Given this list of marker genes MYL4, GMFG, SPHK2, CRAT, FBXO3, BRCA1, APIP, ZDHHC4, FOXI1, CDH10, CYFIP1, GUCA1A, GEMIN7, COPZ1, TBC1D31, ERCC6L, MSRB2, PKD2, OAZ2, PTGR2, VASP, SLK, POC1A, SSU72, ATAD5, NDC80, SCP2, EGFL7, CHEK2, SDHD (succinate dehydrogenase complex subunit D), STRADB, VPS26A, SCMH1, C4orf46, TNFRSF1A, TLR1, TMEM79, N4BP1, RNASE1, NIPA1, VPS13B, TLX2 (NCBI Gene Id 51407), KIF20A, HRH4, LPGAT1, ABCC4, RBMXL2, CACNG2, PLP1, BAZ1B, VPS9D1, BOC, RABIF, ITGB2, NDUFS5, TFPI2, PRELID3B, PARD3B, DSTYK, JUNB (NCBI Gene Id 90482), MAN2B1, OXT, HEBP2, LRRC8D, RAB7A, CAMK2A, TWF2, TPPP3, GRB10, SLC8B1, KLHL2, FLT3, RBKS, TMEM269, LIN9, AMPD2, MLEC, ABCD3, TDRD7, KLF10, C3AR1, SS18L1, ENTPD3, CPT2, NAA60, FOXD4L1, GGA2, TAX1BP3, CUEDC2, OAZ1, SRSF9, ANXA2, C14orf93, IQGAP3, RADIL, ISCA2, CACNA1G, WIPI1, MID1IP1, SORD (NCBI Gene Id 6652), CABLES2, STXBP5, ITPRIPL2, MOAP1, PPP2CB, CPEB4, NETO2, CHRNA5, PLXNB2, SLC9A1, KCNK12, KIF5B, PRSS55, NCAPG2, FHOD3, KPLCE, DPY19L4, NAP1L2, TAL2, HTRA2, HMMR, MORC3, CYP4A22, CDK2 (NCBI Gene Id 1017), HOXA5, VAT1L, SLC36A4, ACOX2, CKAP2L, OPTN, TFEB, ASPHD1, AGTPBP1, PELI2, TRPM2, KNTC1, AMOTL2, BCAR3, TMEM158 (NCBI Gene Id 25907), PIGN, COQ8B, DOCK7, PGAM1, UPP1, NRDC, DCLRE1A, MST1R, TRAK2, ZNF687, PRC1, RAB20, FOXP3, ERLIN2, OR4E2, SLC41A3, ZNF608, CYP1B1, GPR146, HSPA4L, VIPR2, CDKN1A, OLIG3, POPDC2, SLC8A2, HNRNPLL, SPC24, NKX2-6, ELF3, NHERF4, TUBA8, RPUSD1, FLOT1, IQGAP1 (IQ motif containing GTPase activating protein 1), ARHGEF26, ST8SIA6, PRKCD, CASP3, HAUS8, ACTG2, UTS2R, MYL1, SPOP, UBL3, KCNG2, UBTD1, GARIN5A, ARF1, RBP7, FANCB, EXOC3L4, FHIP1B, SMAD2, CLEC10A, ANAPC2, CDK11B, RASSF2, CD300C, GDF11, CMTM7, SUN2, here is a description of the gene set: studied in species Homo sapiens Each fraction of mouse hematopoietic cells was purified by cell sorting from bone marrow of 8-week-old C57BL/6 mice, and its gene expression was analyzed. from publication Konuma T, Nakamura S, Miyagi S, Negishi M, Chiba T, Oguro H, Yuan J, Mochizuki-Kashio M, Ichikawa H, Miyoshi H, Vidal M, Iwama A (PMID 21540074) Genes down-regulated in comparison of NKT cells versus monocyte macrophages. Human Gene Set: GSE27786_NKTCELL_VS_MONO_MAC_DN